The following is a description of a gene set: Mismatch Repair Mouse Gene Set: REACTOME_MISMATCH_REPAIR species: Mus musculus, and this is the list of marker genes: Rpa1, Rpa2, Rpa3, Mlh1, Pold3, Pcna, Pold4, Pms2, Msh2, Exo1, Pold2, Pold1, Msh3, Msh6, Lig1 (NCBI Gene Id 16881)